The following is a description of a gene set: The process whose specific outcome is the progression of a columnar/cuboidal epithelial cell of the intestine over time, from its formation to the mature structure. studied in species Homo sapiens Human Gene Set: GOBP_INTESTINAL_EPITHELIAL_CELL_DEVELOPMENT, and this is the list of marker genes: HIF1A, TLR9, KLF5, IL6ST, MIR29B1, FZD5, SRC (SRC proto-oncogene, non-receptor tyrosine kinase), TIGAR, NKX3-2, YIPF6, TMIGD1, SPDEF, PRDM1, YAP1, HOXA5 (homeobox A5), C1GALT1